Given this list of marker genes Fgf10, Gata3, Sox9, Fgf8, Eya1, Tcap, Stox1, Six1, Hesx1, Get1, Fgfr2, Tbx1, Pax8, Col2a1, Fgf3, Cep290, here is a description of the gene set: The process whose specific outcome is the progression of the otic vesicle over time, from its formation to the mature structure. The otic vesicle is a transient embryonic structure formed during development of the vertebrate inner ear. Mouse Gene Set: GOBP_OTIC_VESICLE_DEVELOPMENT species: Mus musculus